Given this list of marker genes D7Ertd443e, Cdk5rap3, Chek1, Uimc1 (NCBI Gene Id 77298), Babam1, Dtl, Taok3, Brcc3, Blm, Babam2, Cdc14b, Mbtps2, Clspn, Mbtps1, Donson, Brca1, Trim39, Cdkn1a, Foxn3, Taok2, Cdk1, Mbd4, Nop53, Mrnip, Brsk1, Plk1 (NCBI Gene Id 18817), Taok1, Rint1, Fzr1, Ccng1, Brcc3dc, Atm, Mre11a, Syf2, Abraxas1, Creb3l1 (NCBI Gene Id 26427), Ier3, Nbn, Ticrr, Foxo4, Topbp1, here is a description of the gene set: Mouse Gene Set: GOBP_MITOTIC_G2_DNA_DAMAGE_CHECKPOINT_SIGNALING A mitotic cell cycle checkpoint that detects and negatively regulates progression through the G2/M transition of the cell cycle in response to DNA damage. studied in species Mus musculus